The following is a description of a gene set: Human Gene Set: HP_LOCALIZED_OSTEOPOROSIS Localized osteoporosis species: Homo sapiens, and this is the list of marker genes: LHX4, GLI2, HESX1, BNC1, SPIDR, FSHR, FOXA2, OTX2, BMP15, TRAPPC2, NR5A1, POLR3H, MRPS22, HTRA1, MSH4, POU1F1, SOX3, RUNX2, PROP1, NUP107, ZSWIM7, PSMC3IP